The following is a description of a gene set: Mouse Gene Set: GOMF_BILE_ACID_BINDING Binding to a bile acid, a steroid carboxylic acids occurring in bile. studied in species Mus musculus, and this is the list of marker genes: Pygl, Akr1c12, Nr1h4, Akr1cl, Fabp1, Akr1c21, Akr1c20, Akr1c14, Akr1c13, Vdr (vitamin D (1,25-dihydroxyvitamin D3) receptor), Akr1c6, Pla2g1b, Napepld, Akr1c19, Akr1c18 (NCBI Gene Id 105349)